The following is a description of a gene set: studied in species Homo sapiens Genes predicted to be targets of miRBase v22 microRNA hsa-miR-4661-3p in miRDB v6.0 with MirTarget v4 prediction scores > 80 (high confidence targets). Human Gene Set: MIR4661_3P from publication Chen Y, Wang X (PMID 31504780), and this is the list of marker genes: STIM1, PTPRF, TTC9, TFB1M, PPP1R3B, AMACR, ENOX2, SENP3 (NCBI Gene Id 26168), SLC25A23, TM9SF3, PHF8, ORC6, HERC6, CPB2, NDE1, KDM5C, DAZAP2, ZBTB38, NAPG, PRKAB2, CPLX2, GTF2H1, ABCA10, NUDCD2 (NudC domain containing 2), C1orf198, HOGA1, MUC7, COL5A3, MLEC, HLA-DMB, GMEB2, SLITRK3